The following is a description of a gene set: Reactome Pathway: Metal ion assimilation from the host species: Homo sapiens In aerobic conditions iron ions are complexed as Fe3+, while in anaerobic or acidic environments iron is encountered in its more soluble form Fe2+. Enterobacteria have developed mechanisms to collect both types of iron from the environment, and the genes involved are especially seen in pathogenic strains (Miethke & Marahiel 2007, Wilson et al. 2016, Palmer & Skaar 2016). External degradation of heme by hemolysins facilitates iron assimilation. In addition to the acquisition of free iron, enterobacteria take up and degrade heme. Other essential metal ions that are acquired from the host using distinct mechanisms are Zn2+, Mn2+, Co2+, Ni2+ and Cu2+. Apart from direct import of metal ions, the main mechanism of acquisition is complexation of external ions with high-affinity siderophores and subsequent import of the respective complexes. Constitutionally expressed in E.coli are the siderophores enterobactin and hydroxamate. Pathogenic strains usually and additionally synthesize and utilize yersiniabactin, aerobactin, and/or salmochelin. part of: Infection with Enterobacteria, and this is the list of marker genes: fecD, mdtC, znuB, fecE, acrA, dppA, fyuA, entS, fhuC, tolC, hbp, mdtA, fes, fepC, efeU, macA, acrD, fecA, feoA, iutA, exbB, ybtP, fecC, efeB, fepD, feoB, HBB, tonB, dppB, exbD, UTI89_C2180, mppA, chuA, fepG, dppC, dppD, fepB, yqjI, dppF, fepA, fhuD, fhuB, znuC, macB, znuA, fecB, HBA1, acrB, mdtB, espC, yqjH, efeO